The following is a description of a gene set: An abnormality in cerebral electrical activity recorded along the scalp by electroencephalography (EEG) and being identified at multiple locations (foci). Human Gene Set: HP_MULTIFOCAL_EPILEPTIFORM_DISCHARGES Multifocal epileptiform discharges species: Homo sapiens, and this is the list of marker genes: CASK, ACTL6B, SUOX, TBC1D24, PCDH19, PIGA (NCBI Gene Id 5277), DPYD, LRPPRC, ASPA (NCBI Gene Id 443), ARX, GABRG2, SLC25A10, PLCB1, CARS2, CLTCL1, ARFGEF1, KCNMA1, ALDH7A1, SATB1, STXBP1, KCNT1, TUBB2A (NCBI Gene Id 92919), CACNA1G, SPTBN1, MECP2, SLC32A1, SCN8A, FGF12 (NCBI Gene Id 2257), CDKL5 (NCBI Gene Id 6792), SLC12A5, SIK1, GNAO1, GRM7, PLPBP, MED13L, KCNQ2, ADK, ATP1A3, DMXL2, NPRL2, SCN2A, SLC25A22, GABRA1, PPP3CA, PIGT, DEPDC5, MYD88, GNB1, ST3GAL5, GABBR2, DOCK7, CHD2, SCN1A, TRIM8, SCN1B (sodium voltage-gated channel beta subunit 1), NPRL3, SCN9A, PIGQ, PIGP, SPTAN1, TBCK, KCNA1, DOLK (NCBI Gene Id 22845), PNKP, NEUROD2, GRIN1, ALG1